The following is a description of a gene set: part of: Class I MHC mediated antigen processing & presentation species: Homo sapiens Intracellular foreign or aberrant host proteins are cleaved into peptide fragments of a precise size, such that they can be loaded on to class I major histocompatibility complex (MHC I) molecules and presented externally to cytotoxic CD8+ T lymphocytes (CTLs). In the cytosol, CTL-recognized peptides are generated by proteasomes, which exist as a mixture of compositionally distinct complexes. The proteasome complex consists of 20S proteolytic core particle (CP) associated with a regulatory particle (RP) such as 19S RP or PA28 RP (Zhao J et al. 2022; Adolf F et al., 2024; reviewed by Watanabe A et al., 2022). The catalytic subunits PSMB6 (β1), PSMB7 (β2), and PSMB5 (β5) within 20S CP exhibit caspase-like, trypsin-like, and chymotrypsin-like activities, respectively (Vigneron N et al. 2015; Rut W & Drag M 2016). During peptide bond cleavage, threonine from the active site of the catalytic β-subunit binds to the N-terminal peptide fragment forming an unstable acyl-enzyme intermediate, where a peptide fragment remains attached to the proteasome. Subsequently, a water molecule hydrolyzes the bond between the peptide and the proteasome, resulting in the release of the peptide's C-terminal end (Mishto M et al. 2012; Ebstein F et al. 2016; Soh WT et al., 2024). Either one or two regulatory particles (RP) can attach to the 20S CP (Zhao J et al. 2022; Adolf F et al., 2024; reviewed by Watanabe A et al., 2022). The 19S RP binds 20S CP to form the 26S proteasome, which degrades both foreign and self-proteins in the ubiquitin (Ub)- and ATP-dependent manner (Zhu Y et al., 2018; Dong Y et al., 2019; Zhang S et al., 2022; reviewed by Sahu I & Glickman MH 2021a). In addition, a subset of intracellular proteins, especially intrinsically disordered proteins, can directly bind to 20S CP for Ub- and ATP-independent proteasomal degradation (Makaros Y et al., 2023; Mamrosh JL et al., 2023; Pepelnjak M et al., 2024; reviewed by Sahu I & Glickman MH 2021 b; Bialek W et al., 2023). Unlike 19S, the PA28 regulatory particle does not have a ubiquitin receptor; binding of PA28 to the 20S CP promotes Ub-, ATP-independent protein breakdown. PA28 proteasomes are thought to be important for rapid degradation of misfolded proteins under conditions of oxidative stress or degradation of proteins with intrinsically disordered regions (Habib JA et al., 2020; Chen J et al., 2021; Zhao J et al. 2022; reviewed by Thomas T et al. 2023). Various immune cells, such as T cells, B cells, and antigen-presenting cells, constitutively express a specialized form of proteasomes, known as immunoproteasomes, in which the catalytic subunits PSMB6 (β1), PSMB7 (β2), and PSMB5 (β5) of 20S CP are substituted with PSMB9 (β1i), PSMB10 (β2i), and PSMB8 (β5i), respectively (Shin EC et al., 2006; Bai M et al., 2014; Santos R et al., 2017). This variation of the core particle is known as 20S iCP. Immunoproteasomes utilize the PA28 regulatory particle to degrade antigens (Lesne J et al., 2020; Chen J et al., 2021). Under inflammatory conditions, the expression of the catalytic and PA28 regulatory subunits of immunoproteasome is induced by cytokines like interferon-gamma (IFNγ), type I interferons, and tumor necrosis factor alpha (TNF-α). Immunoproteasomes possess enhanced chymotrypsin- and trypsin-like activities, alongside with the reduced caspase-like activity. Reactome Pathway: Antigen processing: Ub, ATP-independent proteasomal degradation, and this is the list of marker genes: PSMB9, PSMA1, PSMB10, PSMB7, PSMB6, PSMA2, PSME2, PSMB3, PSMA7, PSMB8, PSMB5, PSMA6, PSMA3, PSME1, PSMA4, PSMB1, PSMB2, PSMB4, PSMA5